Given this list of marker genes CSAD (NCBI Gene Id 51380), PITPNB, PLXNA4, VPS53, VSTM4, DDIT4L, ECHDC2, EGLN3, UPK1B, CIT, CCL19, PDLIM1, PRKN, CRTAP, SMOC1, PBXIP1, IBSP, MGLL, LRIG3, SEPTIN4, GATA6, FHIP1A, DNAAF8, OMD, ZFYVE26 (zinc finger FYVE-type containing 26), STX3, CREB3L2, SLC48A1, PCSK5, SLC3A2, RASGEF1A, FOXN3, MYLK, CNPY1, CDH13, TBX18, F11R, PDZK1, FZD4, CADM2, SRPRA, RND2, BCAM, DOCK6, MTCL2, NEDD4, AUTS2, ITIH4, DNAJB2, CYTL1, SMPD1, NKD1 (NCBI Gene Id 85407), DNAJB5, TRPM1, NAALADL2, CEP162, KLF4, ABCG4, TNFAIP1, MST1R, PRKD3, CAMK2G, ITPRIP, MSI2, EMSY, EMP2, NPNT (nephronectin), KANK1, GIT2, IL17RE, SBDS, TOP3A (DNA topoisomerase III alpha), LRRC72, MPDZ, MPPED2, CFAP20, SEMA5A, MAP4 (NCBI Gene Id 4134), RPTOR, ATF7, ICE1, ADGRL1, KLF7, GMEB2, SDC2, COLEC11, CELF3, GGPS1, ZNF281, ATP9A, SNORD123, TXNRD3, NUP50, ARL1, OSCAR, SLC41A1, GLIS1, NCOA1, MCF2, CDK13, LRRN4, SFN, IQCE, B3GLCT, NHSL2, DAP3, FAM234B, DCP2, PAMR1, ZDHHC3, GORASP2, IER3, SPOCK1, PRR14, UCHL1, MAP7D1, DDA1, CLDN12, SOCS3, SEMA3C, LGR6, JADE2, TNS1, CTDSP2, KIF26B, ARHGAP44, PALM, MYO1D, ZC3H10, NPR1, NUCB1, LAPTM4B, EHD2, SLIT3, ATXN1L, CYP2U1, TPPP3, RHOJ, TDRD12, DPYSL5, NCAM1, NYX, PGRMC1, MARCHF3, SLC2A12, EPHX1, GIT1, SAXO5, POC5, ZRANB1, RUNX1T1, SEL1L, SBNO2, KPRP, INHBA, TIMP3, FBLN1, LMCD1, SH3PXD2A, LMOD1, HYCC2, RRP1, IRAG1, DAP, MUC15, BACE1, NSUN5, KIF13A, ARHGAP23 (Rho GTPase activating protein 23), FHIP2A, TRIB1, TMEM30B, FBXO34, PHTF2 (putative homeodomain transcription factor 2), PRPF8 (NCBI Gene Id 6108), KCNJ8, PSD, HSD17B11, MAU2, AMOTL1, TRAF3IP2, MCM6, ZNF507, ANP32A, PLBD2, PRELP, CCDC107, DTNA, INPP5A, SDAD1, WNT5B, ARHGEF17, UBL4A, INTS6, PIK3R2, EXT2, PTK2, SGCD, IRS1, BOD1, here is a description of the gene set: Human Gene Set: GSE32533_WT_VS_MIR17_KO_ACT_CD4_TCELL_UP studied in species Homo sapiens miR-17 from the miR-17-92 cluster regulate activation-induced cell death in T cells and modulate inducible regulatory T cell differentiation. We used microarrays to detail the global program of gene expression modulated by miR-17 and aim to identify the potential targets of miR-17. from publication Jiang S, Li C, Olive V, Lykken E, Feng F, Sevilla J, Wan Y, He L, Li QJ (PMID 21972292) Genes up-regulated in activated CD4 T cells: wildtype versus MIR17 knockout.